The following is a description of a gene set: studied in species Mus musculus Mouse Gene Set: GOBP_REGULATION_OF_GROOMING_BEHAVIOR Any process that modulates the frequency, rate or extent of grooming behavior., and this is the list of marker genes: Shank3, Mc4r, Nmu (NCBI Gene Id 56183), Dlg4, Nrxn1, Cntnap4